Given this list of marker genes PDCD1, CCL4L2, CD6, C12orf75, CTSD, CXCR6, RBPJ, CXCL13 (NCBI Gene Id 115545), KLRB1, CKLF, CCL4, PLIN2, ITGB2, ALOX5AP, CLEC2B, ANXA1, CTSW, ID2, PRF1, NKG7, ANXA2, APOBEC3G, CD63, CD99, CST7, GZMM, GNLY, JUN, DUSP4, GZMH, HLA-DRB1, HLA-DPB1, HLA-DPA1, IFNG, ZEB2, CYTOR, GZMA, HLA-DRA, COTL1, ANKRD28, BHLHE40, LGALS1, CCL3, HOPX, GZMK, CCL5, GZMB, CD96 (NCBI Gene Id 337949), LAG3, here is a description of the gene set: studied in species Homo sapiens Genes upregulated in subsets of cells of a given type within various tumors from publication Gavish A, Tyler M, Greenwald AC, Hoefflin R, Simkin D, Tschernichovsky R, Galili Darnell N, Somech E, Barbolin C, Antman T, Kovarsky D, Barrett T, Gonzalez Castro LN, Halder D, Chanoch-Myers R, Laffy J, Mints M, Wider A, Tal R, Spitzer A, Hara T, Raitses-Gurevich M, Stossel C, Golan T, Tirosh A, Suvà ML, Puram SV, Tirosh I (PMID 37258682) In this study, an extensive analysis was conducted to define meta-programs (MPs) capturing intra-tumor heterogeneity across a spectrum of tumor types. The approach utilized non-negative matrix factorization (NMF) to analyze each cell type separately within individual tumor samples. This involved the analysis of malignant cells, macrophages, fibroblasts, endothelial cells, epithelial cells, T-cells, and B-cells. NMF was executed with varying parameter values (K=4, 5, 6, 7, 8, 9), thereby generating 39 programs for each cell type per sample. Each NMF program was summarized by the top genes based on NMF coefficients.\nRobust MPs were then delineated for each cell type using a set of stringent criteria, including recurrence within the same tumor, similarity to programs in other tumors, and non-redundancy within a tumor. Subsequently, these robust NMF programs were clustered (per cell type) based on Jaccard similarity, leading to the identification of MPs associated with each cell type.\nTo enhance the quality of the MPs, a refinement steps were undertaken, involving the removal of MPs suspected of reflecting low-quality data (with an overrepresentation of ribosomal proteins or mitochondrial-encoded genes), single-study inclusion, or similarity to miss-annotated cell types. Human Gene Set: GAVISH_3CA_METAPROGRAM_CD4_T_CELLS_CYTOTOXIC